Given this list of marker genes TRBC2, TRAV27 (T cell receptor alpha variable 27), TRBC1, PTPN6, TRAC, CD3D (NCBI Gene Id 915), CD3E, CD247, CD3G, TRBV19, here is a description of the gene set: A T cell receptor complex in which the TCR heterodimer comprises alpha and beta chains, associated with the CD3 complex; recognizes a complex consisting of an antigen-derived peptide bound to a class I or class II MHC protein. Human Gene Set: GOCC_ALPHA_BETA_T_CELL_RECEPTOR_COMPLEX species: Homo sapiens